Given this list of marker genes RGS16, CPM, ABCA3, FBP1, PTPN13, GKN2, DUOX1, FNIP2, SFTPA1, SELENBP1, SCD, MBIP, GSTA4, S100A14, ETV5, PMM1, DRAM1, CLDN18, CD74, QSOX1, CD44, SLC34A2, SFTPA2, PEBP4, PPP2R5A, HOPX, MUC1, CACNA2D2, AKAP13, PARM1, RNASE1, IRX2-DT, PCDH9, SFTA3, SNX30, TXNIP (NCBI Gene Id 10628), PXMP4, SFTPB, NPC2, MTUS1 (microtubule associated scaffold protein 1), KCNJ15, FASN, LAMP3 (NCBI Gene Id 27074), LRRK2, SFTPC, FABP5, C16orf89, MALL, ROS1, C1orf21, DLC1, CXCL17, ATP8A1, ATP11A, CYB5A, SFTPD, CHIAP2, PGC, CREB3L1, TMSB4X, NECAB3, CRTAC1, ZNF385B, CD81, TXNDC17, SLC22A31, NINJ2, TMEM125, RFTN1, SECISBP2L, LMO3, here is a description of the gene set: studied in species Homo sapiens Human Gene Set: TRAVAGLINI_LUNG_SIGNALING_ALVEOLAR_EPITHELIAL_TYPE_2_CELL from publication Travaglini KJ, Nabhan AN, Penland L, Sinha R, Gillich A, Sit RV, Chang S, Conley SD, Mori Y, Seita J, Berry GJ, Shrager JB, Metzger RJ, Kuo CS, Neff N, Weissman IL, Quake SR, Krasnow MA (PMID 33208946)